Given this list of marker genes CC2D2A, FLVCR2, VANGL1, TMEM237, MKS1, B4GAT1, KIAA0586, CEP55, FUZ, CEP290, B9D1, RPGRIP1L, DACT1, TBXT (T-box transcription factor T), TBX15, WDR81, VANGL2, TXNDC15, RPGRIP1, B9D2, HYLS1, TRIM36, TMEM231, NUAK2, CCL2, TCTN1, HOXD13, NDE1 (nudE neurodevelopment protein 1), TCTN3, SNRPB, CSPP1, KIF7, GPKOW, TMEM67, TCTN2, PHGDH, TMEM216, ESAM (NCBI Gene Id 90952), TMEM107 (transmembrane protein 107), here is a description of the gene set: species: Homo sapiens Anencephaly Anencephaly is a developmental anomaly characterized by a fetus that has no calvarium, with a lack of most or all of the fetus' brain tissue. Anencephaly belongs to a collective group known as neural tube defects (NTD) and is a result of the neural tube failing to close in its rostral end during fetal development. Human Gene Set: HP_ANENCEPHALY